The following is a description of a gene set: from publication Graessmann M, Berg B, Fuchs B, Klein A, Graessmann A (PMID 17160024) studied in species Mus musculus Genes up-regulated in ME-A cells (breast cancer, sensitive to apoptotic stimuli) upon serum deprivation for 22 hr in the presence of medium concentrate (MC) from ME-C cells (breast cancer, resistant to apoptotic stimuli). Impairment of the complex regulatory network of cell death and survival is frequently the reason for therapy resistance of breast cancer cells and a major cause of tumor progression. We established two independent cell lines from a fast growing mouse breast tumor (WAP-SVT/t transgenic animal). Cells from one line (ME-A cells) are sensitive to apoptotic stimuli such as growth factor depletion or treatment with antitumor agents (e.g. doxorubicin). Cells from the second line (ME-C cells), which carry a missense mutation at the p53 codon 242, are very insensitive to apoptotic stimuli. Co-cultivation experiments revealed that the ME-C cells mediate cell death resistance to the ME-A cells. Microarray and Western blot analysis showed that osteopontin (OPN) is selectively overexpressed by the ME-C cells. This glycoprotein is the most abundant protein secreted by the ME-C cells and we obtained strong indications that OPN is the main antiapoptotic factor. However, the OPN containing ME-C cell medium does not alter the expression level of pro- or antiapoptotic genes or known inhibitors of apoptosis (IAPs). Its signaling involves mitogen-activated protein kinase (MAPK)/extracellular signal-regulated kinase (ERK) kinase (MEK)1/2 as the kinase inhibitor PD98059 restores apoptosis but not the Akt inhibitor. In the ME-A cells, mitochondrial cytochrome c release occurs with and without external apoptotic stimuli. OPN containing ME-C cell medium does not prevent the mitochondrial cytochrome c release and caspase-9 processing. In serum starved ME-A cells, the OPN containing ME-C cell medium prevents caspase-3 activation. However, in doxorubicin-treated cells, although apoptosis is blocked, it does not inhibit caspase-3. This indicates that the ME-A cells distinguish between the initial apoptotic stimuli and that the cells possess a further uncharacterized control element acting downstream from caspase-3. Human Gene Set: GRAESSMANN_RESPONSE_TO_MC_AND_SERUM_DEPRIVATION_UP, and this is the list of marker genes: MEST, OGN, PPP1R10, UROC1, PCDHB16, TRIM8, OAS2, KCTD12, CASP7, ENC1, CCL7, CRHR1, SLC24A3, BOC, RBM43, LGALS3BP, IFI35, GHR, ELN, SAMHD1, CMPK2 (cytidine/uridine monophosphate kinase 2), CP, HHAT, NMNAT1, RFXANK, BCR, PHLDB2, IGHG1, EBNA1BP2, MMD, ADAR, IAPP, DCUN1D1, TSPAN33, GBP6, MEPCE, CYP2B6, LCE1B, COL5A2, PCDHB15, SOCS1, MX1, SYCP3, IRF2, PDGFRB, TLR2, RESF1, OAS1, DKK3, ABCC8, COL9A1 (NCBI Gene Id 1297), IFIT1B, PLEC, MYOC, OXA1L, PMEPA1, COL4A3, CDON, PLA2G2E, OSGIN2, GTF3C6, TMEM167A, C3, PARP9, USP18, ACTB, ISG15, KNG1, NKX2-3, TUBB4B, TRIM5, CSF1, TACR2, OSR1, HSD11B2, RBMX, TOR3A, CCL2, TXNDC16, CXCR5, PARP3, FSTL1 (follistatin like 1), LIFR, IRS1, FCGR3A, TRIM34, CAPN6, PSMB10, ZBP1, IFIT2, POU3F4, TMEM140, SELENOP, FAS, AQP1, ZNF670, NNMT, CEP112, DPF3, FBXW2, DAPK2, DNM3 (dynamin 3), CDK5R1, TRAFD1, GSTM5, STAT1, KALRN, THEMIS2, SEPTIN6, RIN2, MIGA2, MNDA, SLFN12, SP100, GRHL2, KCNMB2, BGN, IRF7, FES, ATG10, CNTNAP4, TP53INP1, PTHLH, N4BP2L1, IFIH1, TRIB2, GBP4, HOXB8, COL3A1, VDAC1, RTP4, HELZ2, CFB, TRIM21, GBP2, TOR1AIP1, HOXB7, IFI27, SFXN2, CDCA3, TMPO, BST2, TXNIP, IKBKB, DNAJC27, RNF144B, IGFBP7, UBXN2B, FJX1, HSD11B1, ZNF672, NEDD9, PARP14, IRGM (immunity related GTPase M), LIPA, IHH, DMP1, NEUROG3, RSAD2, IFI44, TLR3, NECAB2, ABI3BP, HIPK2, NACC2, CASD1, STK11IP, DLC1, SENP1, TAP2, ELK1, PRF1, EGF, LY75, RECK, PARP12, USP25, TRIM25, ELOVL4, SP110, KCNA6, APOL1, CD2, IFIT3, PRSS23 (NCBI Gene Id 11098), INHBB, UBA7, DDX60, CCL15, ZNF503, SLC9A8, OASL2P, HLA-B, MRPL57, ANGPT1, SOD2, ADCY3, MOCS1, PDE7A, WFDC21P, PES1, STEAP4, PFDN5, CXCL10, CLIP1, RTL6, ADCY7, EIF2AK2, IRF1, TMT1A, PRELP, IRF9, CCN5, NCL, CPEB3, COL5A3, NCK1, HOXB5, NXNL2, PATZ1